Given this list of marker genes ITGB7 (integrin subunit beta 7), MTURN, IL21, ALPK2, ATP6V1G2, GOLPH3, SOX4, HP1BP3, SMARCA2 (SWI/SNF related, matrix associated, actin dependent regulator of chromatin, subfamily a, member 2), HIPK3, AP3D1, WBP1L, B3GALNT1, SBNO2, CD86, ARRB2 (arrestin beta 2), ZNF658, CRISPLD2, TBCEL, MAP1LC3B, BLOC1S1, PIGV (NCBI Gene Id 55650), ZNF579, PHF21A, MAP4K5, PIP4P2, CLOCK, RBM39, RGCC, SYNRG, MXD4, SLC9A1, PSTPIP1, PLCG1, SPHK1, RBM18 (RNA binding motif protein 18), RTN4RL2, TRPM7, NIPAL1, ABI3, SOBP, UBXN4, FYCO1, LAMC2, CNOT6, STN1, CRTC3, UNKL, FUT11, FRMD6, FKBP1A, STK32B, SLC46A1, GOLGA1, UBXN6, KIDINS220, FAM20A, TFAP2A, SIRT7, LGMN, FAM163A, YWHAH, ASIP, ARHGAP25, EPB41L2 (NCBI Gene Id 2037), C1GALT1 (core 1 synthase, glycoprotein-N-acetylgalactosamine 3-beta-galactosyltransferase 1), CXCR5, ATP6AP1, REXO4, IRF2BPL, SIT1, HPS6, TIMP1, SH3BGRL2, RIN2, PPP1CC, TGFBR2, GABBR1, CREBRF, RNFT1, PRR5L, ZFP28, CCNDBP1, CCDC88C, PTPN4, TSPAN7, MRPL9, TXNDC15, MRPS5, STIM2, IBSP, STARD5, DBNDD2, ITGB2, TSPO, SLC66A2, FERRY3, SPIN1, PDE9A, DDI2, FIRRE, PSAP, UIMC1, PTBP3, ATF7IP, ATAT1, VRK3, HERC2, PRR16, TUBB2B, TP53INP2, H3C14, MATCAP2 (NCBI Gene Id 23366), CDKL3, ARL4C, CLDND1, BEND4, STRA8, ZNF565, ZC3H12A, FAM120AOS (NCBI Gene Id 158293), KRTAP17-1, PIP4P1, NAA16, ERBIN (NCBI Gene Id 55914), SLC9A2 (solute carrier family 9 member A2), UBN2, GOLM1, CPNE1, SLC6A6, FURIN, NLRC3, USE1, DDR1, MAP4K4, ATRN, SIAE, RAD52, SARAF, TFAP2D, CCPG1, SESTD1, KLRD1, EPC2, GRINA, VAV1, AKAP12, CYP11B2, JMY, SEMA5A, GABARAPL1, BMAL1, ITM2B, LRRCC1, SLCO2B1, SKI, ACAA1, SBK1, DDX17, INO80D, NLK, LAT2, VWA5A, COMT (catechol-O-methyltransferase), CNIH1, TMEM176B, CLCC1, CCNL2, ENTPD5, MOG, MPEG1, PGS1, ATP6V1E1, NAPEPLD, TMCO5A, ALOX15, EBP, CAST, DTX4, DGAT2, SESN3, LUC7L3, ETFBKMT (NCBI Gene Id 254013), UBP1, CFAP263, ATRNL1, GMFG, STAB1, BCL2L15, TSG101, CSNK1E, TNIP2, NLRP12, MAGI3, FCHO1, SEMA6D, POU6F1, GDI2, CAMK2N1, CAT, here is a description of the gene set: Human Gene Set: GSE8921_UNSTIM_0H_VS_TLR1_2_STIM_MONOCYTE_12H_DN from publication Liu PT, Stenger S, Li H, Wenzel L, Tan BH, Krutzik SR, Ochoa MT, Schauber J, Wu K, Meinken C, Kamen DL, Wagner M, Bals R, Steinmeyer A, Zügel U, Gallo RL, Eisenberg D, Hewison M, Hollis BW, Adams JS, Bloom BR, Modlin RL (PMID 16497887) In innate immune responses, activation of Toll-like receptors (TLRs) triggers direct antimicrobial activity against intracellular bacteria, which in murine, but not human, monocytes and macrophages is mediated principally by nitric oxide. We report here that TLR activation of human macrophages up-regulated expression of the vitamin D receptor and the vitamin D-1-hydroxylase genes, leading to induction of the antimicrobial peptide cathelicidin and killing of intracellular Mycobacterium tuberculosis. We also observed that sera from African-American individuals, known to have increased susceptibility to tuberculosis, had low 25-hydroxyvitamin D and were inefficient in supporting cathelicidin messenger RNA induction. These data support a link between TLRs and vitamin D-mediated innate immunity and suggest that differences in ability of human populations to produce vitamin D may contribute to susceptibility to microbial infection. species: Homo sapiens Genes down-regulated in monocytes: untreated versus M. tuberculosis 19 kDa lipopeptide (12h).